Given this list of marker genes SAR1B, RAB22A, CYB5R4, PMPCB (NCBI Gene Id 9512), ZBTB11, PCDH7, FIGN, DAPP1, FGD5, MAP3K2, DENND1B, SLC22A23, RND3, CNTN3, KCNB1, NFYA, PLAG1, RGL1, MAP3K14, SLC33A1, LMO3, USP24, NR2C2, EIF2S1, RALGPS2, LAMA3, RAB11A, IKZF2, SLC49A4, OLFM3, ADAM9, ARID4A, QSER1, SETD9, FBN1, LRP5L, MYO19, ADAMTSL3, CYP2U1, ATF2, PICALM, JAZF1, ZBTB7A, TAB3, ZNF75A, PDCD4, GALNT3, USP46 (NCBI Gene Id 64854), C11orf54, SMARCC2, MLIP, CXXC5, EFEMP1, PACC1, CROT, VASH2, PAK5, GXYLT1, KCTD10, SAMD12, KDM1B, NRCAM, CELF2, MDGA2, SOX6, SYTL4 (synaptotagmin like 4), HNRNPA2B1, SYNC, EPC1, TRERF1, TMSB4Y, ADCYAP1, TET3, MBNL2, C2orf69, NHSL3, RB1CC1, DDHD1, ITPR3, SEPTIN2, UBE2Q2, CAMSAP2, RFX7, VLDLR, CNRIP1, GLIS3, FMC1-LUC7L2, CREB5, MUC7, ZZZ3, DENND5B, HSPA14, APP, TLCD3A, LEFTY1, ATXN7, CCDC6, PRC1, ZBTB37, SPRED1 (NCBI Gene Id 161742), RBL1, FBXW11, MTF1, CFL2 (cofilin 2), CUX2, TUBG1, ANKRD50, ASAP2, SP1, IDI2, ATAD2, PRDM4, KIF26B, FYCO1, FNDC3A, NT5C3A, VAMP3, CDK19, RAP1A, OSBPL8, ZNF804A, RDH5, SLCO3A1, TFAP4, PKN2, CAPRIN2, LCOR, ISM2, CDCA7, RARB, LHX6, IL6ST, WDR37, BBIP1, KMT2A (NCBI Gene Id 79951), AMER2, SPOP, DERL2, MARCHF5, LAMP5, TNFAIP1, CDKN1B, CDC25B, LUC7L2, ARID4B, KIF23, EXPH5 (NCBI Gene Id 23086), ARMC8, CACUL1, BICRAL, BAZ1A, FGD4, LRP8, MED12L, YOD1, LDOC1, CNOT11, PRRX1, MCL1, TOM1L2, ITFG1, ZNF213, ZKSCAN1 (zinc finger with KRAB and SCAN domains 1, NCBI Gene Id 7698), TMEM19, ZFYVE26, WNT9B, ASF1B, DYNC1LI2, CILP, JPT1, MNT, CYP26B1, GAS2, IKBIP, PIP4K2A, RASSF2, DCAF6, SS18L1, TNRC6B, GDF11, TET1, SLC24A3, ADCY10, IRF2, PRDM8, AEBP2, ZNF385A, ZNF800, ASH1L, PDIK1L, ZNF367, TIPARP, RCOR3, MEX3A, TP73, ROCK2, COPG2, CDCA4, here is a description of the gene set: Human Gene Set: MIR520F_3P from publication Chen Y, Wang X (PMID 31504780) species: Homo sapiens Genes predicted to be targets of miRBase v22 microRNA hsa-miR-520f-3p in miRDB v6.0 with MirTarget v4 prediction scores > 80 (high confidence targets).